The following is a description of a gene set: species: Homo sapiens The series of molecular signals in which an intracellular signal is conveyed to trigger the apoptotic death of a cell. The pathway is induced in response to hypoxia (lowered oxygen tension). Hypoxia, defined as a decline in O2 levels below normoxic levels of 20.8 - 20.95%, results in metabolic adaptation at both the cellular and organismal level. The pathway ends when the execution phase of apoptosis is triggered. Human Gene Set: GOBP_INTRINSIC_APOPTOTIC_SIGNALING_PATHWAY_IN_RESPONSE_TO_HYPOXIA, and this is the list of marker genes: PIK3CB, ENO1, TP53, PINK1, MAP2K1, BNIP3, ATF2, TMBIM6, NOL3, HYOU1